Given this list of marker genes Map2k6 (mitogen-activated protein kinase kinase 6), Atp2a2, Tnni3, Kcnq1, Kcnj5, Calm3, Atp1a1, Kcne2, Calm2, Srsf1, Adrb1, Dmd, Bin1, Slc8a1, Casq2, Sumo1, Jup, Myh7, Nppa, Ehd3 (NCBI Gene Id 57440), Map2k3, Scn1b, Snta1 (syntrophin, acidic 1), Atp2a1 (ATPase, Ca++ transporting, cardiac muscle, fast twitch 1), Kcne5, Klk1b1, Rangrf, Nedd4l (NCBI Gene Id 83814), Hcn4, Cacna1c, Bmp10, Kcnj8, Adcy10, Smad7, Tnnc1, Fkbp1b, Nkx2-5, Atp1a3, Scn4b, Hsp90aa1, Dlg1, Scn2b, Tnni3k, Kcne1, Myh7b, Slc9a1, Cav1, Uty, Rnf207, Ryr2 (ryanodine receptor 2, cardiac), Grk2, Dsc2, Ccn2, Kcne3 (NCBI Gene Id 80572), Ace2, Trpm4, Mtor, Akap6, Cacna1h (NCBI Gene Id 58226), Calm1, Camk2d, Stc1, Hdac4, Adra1b, Ank2, Rgs2, Dsp, Met, Kcnh2, Scn5a, Sri, Atp1a2, Flna, Gpd1l, Zc3h12a, Myl3, P2rx4, Kcnn2, Zfas1, Gaa, Tmem38a, Psen2, Akap9, Pkp2, Myl4, Agrn, Fxyd1, Strit1, Gja5, Smtn, Fgf13, Ctnna3, Tpm1, Chga, Tnni1, Dsg2, Smad5, Pln, Atp1b1, Kcnj2, Abcc9, Nup155, Scn3b, Cacna1d, Tnnt2, Myl2, Kcne4, Gata4, Kcnd3, Mybpc3, Cacnb2, Gsn, Tmem38b, Tcap, Ucn, Ppp1r13l, Sgcd, Tnni2, Cacna2d1, Myh6, Actc1, Vegfb, 3425401B19Rik, Adora1, Tafazzin, Ttn, Myl1, Csrp3, Cav3, Scn1a, Cxcr4, Pik3ca, Kcna5, Scn10a, Pde4d, Pde5a, Adra1a, here is a description of the gene set: Muscle contraction of cardiac muscle tissue. Mouse Gene Set: GOBP_CARDIAC_MUSCLE_CONTRACTION studied in species Mus musculus